Given this list of marker genes TIA1, MCOLN3, RAD50, GART, STAMBPL1, NAA50, CAMSAP1, FIGN, PSMA5, HYCC1, YARS1, SMC2, DCUN1D1, PPP4R3B, GLRX3P2, CUL4B (cullin 4B), ASAP1, SLC38A1, HRH1, FIGNL1, SLC38A2, XPOT, MSH6, FN1, YWHAZ, GAD1, TPX2, DPH3, ZNF160, VTA1, EPRS1, ANKHD1, UGGT2, ATXN3, PSMA3, CTDSPL2, METTL5, PLSCR1, MTAP, ZNF567, RBM39, STC2, COMMD2, AURKB, PTPN12, MME, TARS1, COPA, TMPO, ZNF317, MED6, QSOX1, CXCL8, ANXA2, MCM8, CCDC88A, MBNL2, HYLS1, TTK, TTPAL, DDX52, STAG1, ZNF655, ADRM1, ADK, TGM2, DNM1L, BORA, CEBPG, MTFR2, WDHD1, RCC2 (regulator of chromosome condensation 2), TOP2A, VCAN, MRE11, SMC6, HSPA9, TAB3, CARS1, IRAK1, WAPL, ATP2B1, SRSF6, CSE1L, NIFK, SNAP25, ESF1, LIG4, ITGA11, GDF15, SLC1A4, MTHFD2L, AIMP1, SESN2, IMPDH1, SCYL2, SUPT6H, UBE3C, SIKE1, ACTL6A, UBE2S, MRPS17 (mitochondrial ribosomal protein S17), AHNAK2, ATRX, ASPM, NDC1, NOP56, MRPL13, KIF14, MAP4K5, ASCC3, ANXA2P2, C18orf54, DSG2, GAS2L3 (growth arrest specific 2 like 3), LPP, CLDN1, MCM4, LINC03124, KMT2C, ELOVL6, TNFSF9, PVR, BBC3, HPS3, TRMT6, TOX2, RPE, RNF175, MIS18A, TAP2, FGFR1OP2, RCC1, SKIC3, F2RL2, GNL2, RIOK2, CELSR3, SLC16A1, PTPN11, SCAND3, TLL2, MFN1, NMI, MYBL1, GLRX, STRN, TNC, BMAL2, HTATSF1, LAMB3, RIGI, RASAL2, NAMPT, API5, SUPT16H, RPAP3, SCHIP1 (schwannomin interacting protein 1), GTPBP2, TAF9, COL7A1, AKIRIN2, EIF4G2, BRAP, SLC7A1, CDC40, ITCH, TPM4, TOPBP1, RBBP6, MOB4, BOD1L1, UTP15, TIGAR, OSBPL8, DSG2-AS1, SF3B1, SRGN, TP53RK, RC3H2, FOXM1, WDR75, RSRC1, PLEC, SCAMP1, SAAL1, TM9SF4, NDUFAF7, DNAJC10, TTC3 (tetratricopeptide repeat domain 3), LACTB, POLR3C, CUL5, CASP4, OGFRL1, NMD3, CWC22 (CWC22 spliceosome associated protein homolog), GAS5, MIOS, SGO2, UBE2C, DIAPH3, CENPA, GNG12, NEMP1, TBL1XR1, C5orf34, WDR17, RLF, MAPK14, PMS1, FAR1, BRIX1 (biogenesis of ribosomes BRX1), MTMR1, QSER1, ZBTB11, MFAP3, ENSG00000187951, CENPU, TUSC3, C5orf24, EIF4A1, MAPK1, NEMF, DNAJC13, PRKAA1, EXOC5, ARHGAP5, EIF4G1, CAPRIN1, MAD2L1, TRMT1, IFIH1, TSC22D2, CTSA, PDRG1, GFM2, PRPF40A, UGCG, ERCC8, NUP58, RAB27B, BZW1, ZCCHC7, IGF2BP2, CSAG3, MITD1 (microtubule interacting and trafficking domain containing 1), RFX3 (NCBI Gene Id 5991), PLK2, SHMT2, PLP2, IFIT3, RALGPS2, RARS1, YIPF5, PSPH, ATP11B, CSNK1D, DEPDC1, CPSF2, PAPOLA, STK17A, NBN, ACAP2, RUNX1, CXCL5, HSPA13, PTBP3 (polypyrimidine tract binding protein 3), BID, LINC00958, UCK2 (uridine-cytidine kinase 2), DENR, SIX4, ENSG00000302531, CALU, WDR36, HSPA4, UBA6, WASHC4, FAM72C, AFF4, USP31, MATR3, HAUS6, FBXO38, AP3D1, JPT1, FAS, L1CAM, ATG12, CDC20 (cell division cycle 20), ATR, ST3GAL6, CENPE, USP10, TGFB1, KIF20B, APCDD1L-DT, FBXO22, NPM1, CCT6A, RBMS1, PSMD12, SYTL2, TMEM158, ESYT2, CXCL1, FXR1, RHOBTB3, RSF1, GABPB1, HDAC9, NLN, RPF2, GTF2H2, KRT80, LARS1, STX16, ARHGAP11A, CPSF3, SNHG26, PPP1R14B, ANLN, EFL1, DDX27, LINC00662, TWF1, PLCB1, ORC6, LMAN1, TPR, HMMR, CENPF, ORC5, PGM3, TOR1AIP2, MCM7, BCLAF1, IFT80, ASNS, AHNAK, TTC39C, S100A2, DBF4, CEP55, UHMK1, MKX, PNMA2, ADAM10, ZNF138, U2SURP (U2 snRNP associated SURP domain containing), GPT2, TPBG, USP15 (ubiquitin specific peptidase 15), HOXB7, SKA3, PRR11, MCM2, PUM3, H2AC11, B4GALT5 (NCBI Gene Id 9334), MOB1A, ACOT13 (NCBI Gene Id 55856), CSNK1A1, KLHL5, IER3, TXNRD1, KIF2A, DEPDC7, PPP2R3C, MORF4L2 (mortality factor 4 like 2), STAM2, SSR3, LINC00511 (long intergenic non-protein coding RNA 511), CTHRC1, GPX8, STIP1, G2E3, CCNB1, EIF4A2, NUP107, ZNF92, ZNF616, CIP2A, FADS3, TXNDC9, VPS26C, IFI16, SP100, IDS, DUXAP8, LCTL, RAE1, IFIT2, H3C10, ELF4, NCBP1, ZNF780B, ANAPC1, FRMD5, SLC16A3, SEL1L, SLC1A5, ETV5, SPIRE1, NOL8, NUF2, RECQL, SAMD9, CEP57, NEK2, TRMT5, SATB2-AS1, MELK, ARL4C, LNPEP, MRPL47, EVA1A, ZNF131, MKKS, KCTD5, OGFOD1, MAGEA5P, CCT2, NRAS, E2F7, ZNF700 (zinc finger protein 700), CORO1C, CMSS1, KIF5B, PLK4, CD58, DPM1, SKA2, LRIF1, NOG, LINC00973, AREG (amphiregulin), DHX9, SMC3, AMMECR1, TPTE, PNN, XRN2 (NCBI Gene Id 22803), RNF6, STIL, GFPT1, LEO1, NIPBL, CHEK1, BCL2L1, TRUB1, AK4, NXPH4, FYTTD1, OXR1, SRGAP2B, MBNL1, USP16, NME7, ADORA1, BUB3, SSB, SRPK1, CBX3 (NCBI Gene Id 82756), TMEM30A, EIF5, PAICS, CHAC2, NCBP2, CKS2, BRCA2, HK2 (NCBI Gene Id 3099), DBT, PRIM2, WARS1, PAGE1 (NCBI Gene Id 8712), CDKN2A, CNOT1, TNFRSF10B, DDX39A, NUSAP1, BCHE, PEG10, DUSP5 (dual specificity phosphatase 5), SLC7A11, TOMM70, LCORL, TMOD3, RESF1, AURKA, BLZF1, USP47, ITGB1, DHX36, EIF2S2, GPR39, TUBGCP3, MAGEA3, ADORA2B, TNFRSF12A, SNHG12, USP1, ZWILCH, RBM34, USP34, POLR1F, RTCA, ATP13A3, DYNC2H1, LINC00342, TLK1, RIF1, XRCC4, PIK3CA, NAA15, DSE, MLF1, RBBP8, HSPD1, SSX2IP, S100A11P1, EEF1E1, BRCC3, ENO1, FEN1, GLRX3, ZNF644, ARFGEF2, GALE, MICB, CDK6, MAGEC2, RBAK, ATG5, CKAP2, ZNF146, TANK, ECT2, ZNF367, DNTTIP1, DLG1, KIF18A, XRN1, RALGAPB, EIF2S1, ULBP2, SRGAP2, ZNF675 (zinc finger protein 675), HECTD1, TMEM167A, CKAP5, SP140L, KPNA4, ZMYND19, RACGAP1, NFE2L3, IL1RAP, ACP1, HOXB9, BTAF1, ADGRF4, GSK3B, FAF1, MAGEA1, SNRPB, ROR1, RPS27A, ZDHHC20, RNGTT, PSMD14, MAGEA12, TRIB3, DCBLD2, MPHOSPH10, HMGA2 (NCBI Gene Id 8091), POLH, PRP4K, RPS6KB1, LIF, KIF11, TUFT1, ZIC1, CCZ1, APC, DNMT1, SLC7A5, STK38, GNAI3 (NCBI Gene Id 2773), GTPBP4, PSAT1, EIF4EBP1, TRIM36, CAMK2N2, GMFB (NCBI Gene Id 2764), KCNMA1, VMA21, MRPS30, PCDHGC3, MRPL42, KPNA2, CDC5L, AGPS, IFRD1, PFDN4, KNL1, DNTTIP2, ONECUT2, USO1, SEMA3C, RAD51AP1, RUNX2, FLNA, GTPBP10, IARS1, HAUS3, TMEM259, CDC42EP3, SMURF1, CEBPZ, CSNK1G3, EIF5B, PLAU, FKBP15, TRIO, OSBPL10, OSER1, SEMA3A, TOP1, LDLR, CHML, ZNF91, CAST, ST6GALNAC5, BUB1B, STK4, PAK2, INHBE, AMIGO2, CLIC4, CBFB, LYAR, BRWD1, SERPINH1, MICAL2, NDC80, RARS2, VPS50, ZNF600, ANKRD1, SMC4, UBXN4, PNPT1, EREG, TFAP2A, IQGAP1, CDK1, GPR158, ACTR2, VPS35, MOCOS, SLC2A1, CYTOR, CDH2, FBXO11, C3orf80, BIRC3, XAF1, RAB32, NUDT21, LIN9, HSP90AA1, ATAD2, NBPF14, DDX3X, MTHFD2, ZBTB38, CDYL, HERC4, RRAS2 (NCBI Gene Id 22800), SLCO4A1, TGFBR1, MED8, DKK3, SLFN5, CDK7, FBXO32, ENC1, EGFR (epidermal growth factor receptor), RND3, MTHFD1L, FBXO45, IRAK2, LZIC, LGALS8, ERLIN1, PPWD1, NABP1, CREB5, ZNF549, REXO2, TFRC, WDR53, STK17B, PMAIP1, MOSPD1 (NCBI Gene Id 56180), PHIP, CEP63, IGF2BP3, MIPOL1 (mirror-image polydactyly 1), RFC1, FAM168B, GOPC, GOLT1B, PCNX4, SENP5, ITPRID2, EIF5A, ZNF184, THOC2, here is a description of the gene set: from publication Rodrigues RF, Roque L, Krug T, Leite V (PMID 17406368) species: Homo sapiens Human Gene Set: RODRIGUES_THYROID_CARCINOMA_ANAPLASTIC_UP Information on gene alterations associated to poorly differentiated (PDTC) and anaplastic thyroid carcinomas (ATC) is scarce. Using human cancer cell lines as a tool for gene discovery, we performed a cytogenetic and oligo-array analysis in five new cell lines derived from two PDTC and three ATC. In PDTC we evidenced, as important, the involvement of the MAPK/ERK kinase pathway, and downregulation of a group of suppressor genes that include E-cadherin. In ATC, downregulation of a specific group of oncosuppressor genes was also observed. Our ATC cell lines presented chromosomal markers of gene amplification, and we were able to identify for the first time the nature of the involved amplicon target genes. We found that the main molecular differences between the two cell line types were related to signal transduction pathways, cell adhesion and motility process. TaqMan experiments performed for five amplicon target genes and for two genes, which allowed a clear distinction between ATC and PDTC: CDH13 and PLAU corroborated array results, not only in the cell lines, but also in an additional set of primary 14 PDTC and three ATC. We suggest that our findings may represent new tools for the development of more effective therapies to the hitherto untreatable ATC. Genes up-regulated in anaplastic thyroid carcinoma (ATC) compared to normal thyroid tissue.